Given this list of marker genes ARHGDIB, TUT7, ARPC5, GMFG, CD53, ACAP2, PAK2, ELF4, PHF21A, RAF1, USP3, WAS, CNOT8, TYK2, STAT6, MYD88, SELL, DOCK2, OSBPL8, ACTR2, CAPZA1, ARPC3 (actin related protein 2/3 complex subunit 3), ADAM10 (NCBI Gene Id 102), ACTR3, VAV1, BNIP2, HCLS1, FMNL1, here is a description of the gene set: Neighborhood of PAK2 species: Homo sapiens Human Gene Set: GNF2_PAK2 Neighborhood of PAK2 p21 (CDKN1A)-activated kinase 2 in the GNF2 expression compendium